The following is a description of a gene set: Mouse Gene Set: REACTOME_GLYCOPROTEIN_HORMONES species: Mus musculus Glycoprotein hormones, and this is the list of marker genes: Inhba, Cga, Tshb, Inhbc, Inhbb (inhibin beta-B), Fshb, Inha, Lhb, Inhbe